Given this list of marker genes RRM2B, EYA1, AIP, NKX2-1, IYD, TPO, DUOXA2 (dual oxidase maturation factor 2), DUOX2, AKT1, PTEN, FOXI1, ALMS1, PIK3CA, KCNJ10, KLLN, MINPP1, MMP14, IDH1, SLC5A5, GNAS (NCBI Gene Id 82944), DNAH1, TSHB, CDKN2B, CACNA1S, SIX5, USF3, MAD1L1 (NCBI Gene Id 8379), POLG, TG, SAA1, PDE11A, MEN1, IDH2, PRKAR1A, KEAP1 (NCBI Gene Id 9817), SLC26A4, TRHR, SLC25A4, SIX1, TWNK, SEC23B, RCBTB1, PAX8, GPR101, MMP2, CDKN1B, SASH1, SDHC, CDH23, CDKN1A, CDKN2C, SDHD, KCNJ18, RET, FOXE1, HABP2, THRB, POLG2, DICER1, TSHR, SDHB, SUGCT, here is a description of the gene set: Human Gene Set: HP_GOITER Goiter An enlargement of the thyroid gland. studied in species Homo sapiens